Given this list of marker genes DLG5, SOX9, TBX2, TNF, FGF10, HMGA2, BMP4, RDH10, HOXA5, EXT1, CTNNB1 (catenin beta 1), RSPO2, WNT2, SPRY2, LAMA1, SPRY1, CELSR1, ESRP2, WNT2B, DAG1 (NCBI Gene Id 1605), HHIP, TNC, FGFR2, YAP1, CTSH, CTSZ, FOXA1, VANGL2, NKX2-1, FOXF1, SHH, KRAS, here is a description of the gene set: The process in which a highly ordered sequence of patterning events generates the branched epithelial tubes of the lung, consisting of reiterated combinations of bud outgrowth, elongation, and dichotomous subdivision of terminal units. Human Gene Set: GOBP_EPITHELIAL_TUBE_BRANCHING_INVOLVED_IN_LUNG_MORPHOGENESIS species: Homo sapiens